The following is a description of a gene set: Human Gene Set: HP_URETEROPELVIC_JUNCTION_OBSTRUCTION studied in species Homo sapiens Ureteropelvic junction obstruction Blockage of urine flow from the renal pelvis to the proximal ureter., and this is the list of marker genes: SF3B2, NSD1, KDM6A (NCBI Gene Id 7403), SLC26A1, EHMT1, APC2, ZMYM2, SIX1 (NCBI Gene Id 6495), PIGL, DSTYK, YY1, HOXA13, GNB1, SLC35A2, TBX18, KMT2D, BRF1, HNF1B, DHCR7, SIX5, EYA1, SOX17, MYOD1 (myogenic differentiation 1)